Given this list of marker genes SMG9, UPF2, SKIC2, SMG1, NCBP1 (nuclear cap binding protein subunit 1), EIF3E, SKIC8, GSPT1, SMG5 (SMG5 nonsense mediated mRNA decay factor), EIF4A3, GSPT2, NCBP2, PYM1, DCP2, UPF1, PNLDC1, UPF3B, SKIC3, DCP1B, MAGOH, UPF3A, MAGOHB, SECISBP2, DHX34, RBM8A, A1CF (NCBI Gene Id 29974), NBAS, RNPS1, SMG7, DCP1A, SMG6, CTIF, PABPC1, PNRC2, APOBEC1, RC3H1, ETF1, SYNCRIP, PARN, HNRNPAB, SMG8, PNRC1, EXOSC10 (NCBI Gene Id 8619), CASC3, ZC3H12A, here is a description of the gene set: species: Homo sapiens Human Gene Set: GOBP_NUCLEAR_TRANSCRIBED_MRNA_CATABOLIC_PROCESS_NONSENSE_MEDIATED_DECAY The nonsense-mediated decay pathway for nuclear-transcribed mRNAs degrades mRNAs in which an amino-acid codon has changed to a nonsense codon; this prevents the translation of such mRNAs into truncated, and potentially harmful, proteins.